The following is a description of a gene set: Genes up-regulated in peripheral blood mononuclear cell non-responders vs responders in adults (<50) after exposure to Heptatitis B surface antigen vaccine (HBsAg), time point 0, 3, 7, 28 and 35 jointly. Comment: these genes were upregulated at all five timepoints from publication Qiu S, He P, Fang X, Tong H, Lv J, Liu J, Zhang L, Zhai X, Wang L, Hu Z, Yu Y (PMID 29580160) studied in species Homo sapiens Human Gene Set: QIU_PBMC_HEPTATITIS_B_SURFACE_ANTIGEN_AGE_UNDER50_NON_RESPONDERS_VS_RESPONDERS_0_TO_35DY_JOINTLY_UP Individuals fail to elicit protective antibody after hepatitis B vaccination remain at risk for hepatitis B virus infection. Analysis of the transcriptome of peripheral blood mononuclear cells (PBMCs) is essential to elucidate the characteristics of gene expression in non-responders. In this study, we enrolled seven responders who had received three injections and seven non-responders who had six injections of hepatitis B vaccine before. All the participants were then vaccinated with a three-dose boost regimen. Microarray analysis and Luminex assay were applied to examine mRNA expression and Th1/Th2/Th9/Th17/Th22/Treg cytokine and chemokine profiles in non-responders and responders. Differentially expressed genes in PBMCs of non-responders at 5 time points, i.e. pre-vaccination, 3<sup>rd</sup>, 7<sup>th</sup>, 28<sup>th</sup> day post the first dose vaccination and 7<sup>th</sup> day post the second dose vaccination indicated a dense network trend. Compared with responders, nine coding genes (BPI, DEFA1B, DEFA4, CEACAM8, MMP8, FOLR3, LTF, TCN1 and TKTL1) were significantly up-regulated in non-responders at all 5 time points, which could probably be the characteristic genes in hepatitis B vaccine non-responsiveness. Gene ontology analysis revealed that most of the DEGs were related with immune responses. Validation results of these genes using quantitative real-time polymerase chain reaction were mostly consistent with the results of microarray. Cytokine analysis demonstrated that IL-27 and CXCL12 concentrations in responders were significantly higher than non-responders on the 3<sup>rd</sup> day after the first dose and 7<sup>th</sup> day after the second dose of vaccination, respectively. No significant difference was observed in other cytokine and chemokine signatures between the two groups. In conclusion, our results revealed characteristic transcriptome and cytokine changes in hepatitis B vaccine non-responders after boost immunization., and this is the list of marker genes: BPI, DEFA4, LTF, TCN1 (NCBI Gene Id 6947), TKTL1, DEFA1B, FOLR3, MMP8, CEACAM8